Given this list of marker genes Gsto2, Ugt1a6a, Ero1a, Selenon, Slc23a2, Akr1a1, Gsto1, Atp1a2, Akr1b1, Gulo, Clstn3, Atp1a3, Gclc, Rgn, here is a description of the gene set: studied in species Mus musculus Mouse Gene Set: GOBP_L_ASCORBIC_ACID_METABOLIC_PROCESS The chemical reactions and pathways involving L-ascorbic acid, (2R)-2--4-hydroxy-5-oxo-2,5-dihydrofuran-3-olate; L-ascorbic acid is vitamin C and has co-factor and anti-oxidant activities in many species.